The following is a description of a gene set: Human Gene Set: MIR9903 from publication Chen Y, Wang X (PMID 31504780) Genes predicted to be targets of miRBase v22 microRNA hsa-miR-9903 in miRDB v6.0 with MirTarget v4 prediction scores > 80 (high confidence targets). studied in species Homo sapiens, and this is the list of marker genes: GPC6, PXMP4, ZNF705EP, KTN1, EXOC4, TMTC1, CRACDL, PPCS, VWA2, SLC39A6, MYO1B, CDKN2AIP, CCDC174, CDK13, RIMS1, CEACAM5, SAXO2, KHSRP, MACROD2, MLEC, AKAIN1, FAM89A, KHK, EIF5AL1, SEPTIN7, NEGR1, ENOSF1, SGCZ, CEACAM8, PRR7, PRTG, PKNOX1, APRG1, RASL12, C20orf203, ZXDB, PTX3, EIF3J, ARHGEF33, SLC6A1, RBL1, ATIC, C2CD6, GRIN2A, FUT9, C8orf58, ZXDA, IGFBP3, ST13, TMEM178B, LZIC, SLC50A1